Given this list of marker genes IL1B (NCBI Gene Id 3553), ALOX12B, IL24, STAT1, PIK3CA, IL6, NFKB1 (nuclear factor kappa B subunit 1), IL19, IL18RAP, CD3E, IL12B, STAT5A, IL18R1, IL2, JAK2, NOS2, CXCL1, IL17F, TNF, SOCS3 (NCBI Gene Id 9021), CD4, STAT4, IFNG, IL23R, IL23A, ITGA3, PIK3R1, RELA, IL12RB1, MPO, IL17A (interleukin 17A), IL18, STAT3, NFKBIA, TYK2, CCL2, CXCL9, here is a description of the gene set: species: Homo sapiens from publication Schaefer CF, Anthony K, Krupa S, Buchoff J, Day M, Hannay T, Buetow KH (PMID 18832364) IL23-mediated signaling events Human Gene Set: PID_IL23_PATHWAY